The following is a description of a gene set: species: Mus musculus Any process that results in a change in state or activity of a cell (in terms of movement, secretion, enzyme production, gene expression, etc.) as a result of an oxygen-containing compound stimulus. Mouse Gene Set: GOBP_CELLULAR_RESPONSE_TO_OXYGEN_CONTAINING_COMPOUND, and this is the list of marker genes: Fpr-rs6, Lhcgr, Slc9b2, Mgarp (mitochondria localized glutamic acid rich protein), Snx5, Htr4, Cps1, Zfp106 (NCBI Gene Id 22647), Birc5, Large1, Mir23a, Agtr2, Nos3, Mir29b-2, Gbp2, Sorbs2, Csrp3, Brinp2, Stat5a, Htr2a, Cul3, Sirt6, Anxa1, Rapgef2, Slc2a5, Gnai1, Ptger4, P2ry12, Zc3h12a, Mir320, Cers1, Cdc5lrt6, Ctsd, Mir467d, Cd55, Mir431, Kank1, Ly6a, Msn, Mup4, Cfh, Dnmt1, Chrne, Zbed6, Tead2, Chrnb1, Blvrb, Psen1 (presenilin 1), Ppm1e, Hcn4, Plscr1, Pcsk9, Acaca, Ly86, Ppp1r9b, Akt1, Fgf23, Gper1 (NCBI Gene Id 76854), Pcna, Cyfip1, Klf16, Lcor, Hdac8, Ddias, Rps3, Pax6, Hmgcr, Map4k4, Oprm1, Slc12a2, Cacnb1, Tbc1d4, Lcn2, Mir29a, Gstp1, Pdcd4, Spidr, Brinp1, Mir208b, Rps6kb1, Plcg2, Ccl2, Kcnc2, Drd4, Ephb3, Mup3, Agtr1b, Ercc6l2, Kcnb1, Mir202, Npr2, Socs3, Acod1, Pik3r2, Trpa1, Crh, Mir30b, Pax2, Mettl21c, Sirt1, Txn1, Gpr39, Brip1 (BRCA1 interacting protein C-terminal helicase 1), Mir296, Rhoq, Trim41, Ddx11, Slurp2, Mir376c, Adh4, Prkn, Fbn1, Drd3, Htr7, Adipor2, Rack1, Ankrd1, Cdc5lrt1, Rps6, Stx4a, Akap9, Cd55b, Gclm, Gpr173, Irgm1, Slc26a3, Arid5a, Snx6, Twf2, Mir496a, Mir224, Kcnmb1, Prkci, Pabpn1, Eprs1, Mt3, Eif4e, Nr2c2, Ly6g6e, Stat5b, Ptpn2, Ndufa13, Ugt1a1, Cxcl16, Ncoa6, Rock1, Lin28a, Chrng, C2cd2l, Selenot, Erbb2, Wnt5a, Ptpn22, P2ry6, Nr1h4, Htr2b, Tgfb1, Pik3ca, Mir9-1, Htr3b, Rab11fip2, Drd1, Tesc, Prkca, Il36rn, Slc6a4, Phip, Prkd1, Ptgfr, Mir323, Nr1h3, Cldn1, Nadk, Mir544, Irf8, Chrm4, Ggcx, Htra2, Gjb6, Pink1, Lrp5, Fam114a1 (NCBI Gene Id 68908), Igf1r, Nr3c2, Marcks, Socs1, Klf4, Tnc, Klf2, Ano1, Lgmn, Eif4ebp2, Ly6g6d, Rapgef1, Igtp, Oxr1, Rgs10, Map3k7 (NCBI Gene Id 93774), Slc26a6, P2rx3, Rnf146, Adcy6, Scnn1b, Aqp8, Jak3, Epsti1, Htt, Rgs9, Mstn, Epha8, B2m, Pih1d1, Adcy7, Mir27a, Mir654 (NCBI Gene Id 100124453), Mir130a, Trim55, Add1, Ctr9, Mir223, Ripk1, Net1, Litaf, Lpin2, Vamp2, Smo (NCBI Gene Id 319757), Cdkn2a, Mir16-2, Casp1, Foxo3, Agap3, Mir511, Hnrnpu, Casp9 (NCBI Gene Id 12371), Agap2, Glra1, Rptor, Ednrb, Kcnk2, Bcar3, Pdx1, Mir1897, Akt3, Foxp1, Shoc2, Lpin1, Mapk13, Mir107, Mir217, Gclc, Slc12a7, Mir672, Cygb, Ogg1, Wnt10b, Mtr, Gria1, Prkcd, Defa23, Nfkb1, Trim12a, Hspa8, Gnaq, Defa24, Fgfr2, Traf6, Pde3a, Adcy3, Fut7, Slc8a3, Yes1, Klf7, Ptpn11, Tifab, Foxa1, Dynap, Ezr, Ces1c, Pdgfra, Mgst1, Glp1r, Mif, Hmgcs2, Cd68, Prdx3, Prkar1a, Tshr (NCBI Gene Id 22095), Calcrl, Ptk2b, Ntrk2, Lmnb1, Ncstn, Smyd3, Smad2, Hcn3, Trerf1, Piwil4 (NCBI Gene Id 330890), Shpk, Rnf4, Got1, Esrra, Bcr, Aldh2, Ppbp, Lep, Nanog, Hrh4, Epha10, Timeless, Traf2, Irak1, Mir376a, Tut4, Golph3, Grb14, Sipa1, Rad51, Ehmt2, Rhob, Cpt1a, Capn2, Defa35, Mir152, Aqp4, Cd80, Atp2b4 (ATPase, Ca++ transporting, plasma membrane 4), Fxn, Gpx1, Castor1, Nfkbib, Mir376b, Dtnbp1, Defa2, Defa39 (defensin, alpha, 39), Prmt5, Sos1, Malt1, Cav2, Map2k6, Pou4f1, Tnip2, Klrk1, Hmga1, Defa25, Zfp36l1, Trpm5, Anxa5, Bad, Rab11fip5, Havcr2, P2ry4, Mmp2, Pdxp (pyridoxal (pyridoxine, vitamin B6) phosphatase), Sybu, Pdk2, Vsnl1, Abl2, Vim, Defa30, H2az1, Trim72, Vps54, Mir486, Cacna1d, Atp5f1a, Igfbp1, Slc5a5, Rps6ka2, Epha3, Brsk2, Glra3, Crtc1, Orai1, Mir155, Bglap3, Atp2b1, Cib2, Bpi, Atg7, Pde4d, Slc29a1, Cx3cr1, Abcc8, Tlr9 (toll-like receptor 9), Slc1a1, Mir194-1, Ly6m, Prkdc, Lepr, Mir194-2, Pdgfb, Cxcl15, Kcne1, Ramp3, Ryr3, Egfr, Trim30b, Gkap1, Sco1, Mir362, Oaz1, Mir181b-2, Halr1, Gjb2, Plaa, Atp1a3, Pde4c, Mir23b (NCBI Gene Id 387217), Hoxa2, Nkx6-1, Map2k7, Gpd1, Cebpe, Pak1, Musk, Icam1, Gramd1b, Rorc, Gch1, Prnp, Actb, Trem2 (triggering receptor expressed on myeloid cells 2), Mir383, Cyp11b1, Ghsr, Adrb2, Egr1, Mir409, Gna14, Tbc1d1, Inhba, Cpeb1, Chrm5, Akap6 (A kinase anchor protein 6), Cdc5lrt5, Cacna1a, Chrm3, Ccl28, Mir30c-1, Bmi1, Raf1, Dnai1, Mup11, Hnrnpk, Rfx6, Mdm2 (NCBI Gene Id 69330), Ptpn6, Dhx36, Ager, Lrrk2, Igf2, Ccr5, Mir337, Ect2, Usf2, Vps35, Slc38a2, Tlr4, Abcb1a, Dgkq, Mup2, Mir192, Zfp683, Pycard, Grb10, Taar1, Lncbate10, Kcnk4, Ly6g6g, Trim63, Cyp24a1, Dnm2, Upf1, Pip4k2a, Ly6g2, Mir598, Mirlet7g, Cul7, Spp1, Cmpk2, Ghrl, Cd300lb, Hsf1, Ahsg, Recql5, Akap7, Defa37, Ly6h, Echdc3 (enoyl Coenzyme A hydratase domain containing 3), Romo1, Mir425, Gprin3, Socs7, Mir30e, Cyp1b1, Postn, Meiosin, Creb1, Lpar1, Il36b, Defa41, Dapk1, Rara, Mir494, Glp2r, Zbtb20, Adipoq, Rela, Id3, Ptgs2, Ptprj, Apoa4, Bcl10, Raet1d, Plcb1, Oxct1, Gbp2b, Nucks1, Sri, Kdm1a, Sgcb, Thbs1, Chrna6, Fancb, Ide, Adrm1, Mmp8, Crygf, Cdc5lrt9, Aldh1a7, Cacna1e, Xrcc5, Anxa7, Nucb2, Gdap1, Rragd, Gfi1, Ywhag, Mmp9, Il36a, Slc39a14, Trp53, Cdk1, Mir30a, Mir146b, Sgk1, Gcgr, Spi1, Defa5, Psca, Inhbb, Phex, Atp7a, Myod1, Chrm2, Btk, Trap1, Ros1, Epha5, Cflar (NCBI Gene Id 98571), Foxo1, Oser1, Eif4ebp1, Pdcd1lg2, Ppef2, Rorb, Trim24, Mpc2, Ly6f, Pde8b, Gas6 (NCBI Gene Id 14456), Chrna5, Pid1, Aldh1a1, Snw1, Sesn2, Mir410 (NCBI Gene Id 723863), Nfe2l2, Mertk, Mir200a, Grin2d, Cpeb2, Becn1, Cx3cl1, Epha4, Shmt1, Mir15a, Irs2, Zdhhc7, Kit, Ncoa1, Max, Chrna3, Mir484, Il1b, Prkcq (protein kinase C, theta), Adipor1, Chrna7, Epha1, Ptprv, Tet1, Mir379, Phox2b, Akt2, Trpc6, Fpr2, Chuk, Tbx1, Cdc5lrt7, Dab2ip, Agtr1a, Gdnf, Chrnb4, Pex2, Mir9-3 (microRNA 9-3), Ankk1, Eny2, Mir24-1, Ghrhr, Akr1c12 (aldo-keto reductase family 1, member C12), Smarcc1, Gja1, Grb7, Sstr1, Sesn1, Mapk3, Wdtc1, Inppl1, Mir369, Irak4, Inpp5k, Ly6c2, Zfand1 (NCBI Gene Id 99875), Ces1f, Ctnnb1, Cxcl13, Plscr3, Tjp1, Uchl3, C1qtnf12, Syk, Defb25, Aanat, Adprs, Defa29, Ruvbl2, Gna15, Trim30a (NCBI Gene Id 20128), Hdac2, Agt, Crhr2, Parp1, Ncoa2, Crhr1, Syap1, Insig2, Chek2, Hes1, Cyp11a1, Fcgr2b (NCBI Gene Id 98391), Gramd1c, Six1, Sesn3, Stk25, Csk, Irf3, Jup, Rab8a, Scimp, Irf1 (NCBI Gene Id 16362), Gnai3, Trpm4, Oprd1, Ubr2, Fam210b, Trp53inp1, Trim12c, Pjvk (pejvakin), Cyp11b2, Ptch1, Srf, Trib1, Mrc1, Rgs8, Ptpra, Mir22, Mirlet7a-2, Flt4 (NCBI Gene Id 14257), Tnip3, Mpv17, Psap, Prpf8, Rbm4, Mst1r, Ces1a, Dynll1, Nod2, Stim1, Fer, Cd14, Gramd1a, Gsk3a, Cdh1, Slc7a5, Il6, Abca1, Rhoa, C2cd5, Efnb2, Pla2g6, Prmt1, Cfl1, Ceacam1, Sos2, Itga2, Irak3, Gpam, Rb1, Socs2, Osr1, Capn10, Npas4, Ins2, Tbx2, Mir30c-2, Fbp1, Ptpn1, Zfp703, Cxcl9, Ccs, Ptgdr, Amigo1, Defa3, Bcl2l2, Cdc5lrt8, Lpl, Ezh2, Gbp6, Akr1c18, Myog, Git1, Pdia3, Myo5a, Nono, Mir199a-1, Ppp3ca, Cdk4, Gjb3, Serpina12, Nck1, Mir667, Irak2, A1bg, Mir142, Pparg, Ly6i, Mir487b, Srebf1, Mir7-1, Casp7, Mir342, Rab34, Zfp36, Ip6k2, Smad4, Fpr-rs4, Gria2, Car2, Mir29c, Il18, Keap1, Prkcb, Epha6, Rapgef3, Mir140, Ang2, Vcp, Nrip1, Ncam1, Fdx1, Irs1, Slc12a6, Adcy8, Jak1, Rplp0, Yap1, Ltf, Mir495, Plscr4, Slc30a10, Cltrn, Cav1, Kcnq1, Erbb4, Ndel1, Mir29b-1, Nfkbia, Sox10, Gprc6a, Trex1, Gata1, Rora, Unc13b, Chrnd, Hcn1, Pck1, Rgs4, Ephb2, Mir205, Defb21, Osbpl8, Map4k1, Tra2b, Mir3099, Hmgb1, Cryge, Ireb2, Blvra (NCBI Gene Id 70105), Rdh12, Txndc2, Tyro3, Ogt, Prdx1, Ankrd26, Appl1, Vcam1, Zfp277, Ep300, Cebpb, Mt1, Hnrnpd, Lilrb4a, Ccdc186, Akap8, Kcnj11, Hras, Rarg (NCBI Gene Id 19411), Twnk, Gpr37, Mir26b, Slc2a2, Hadhb, Actn2, Ltk, Ctnna1 (NCBI Gene Id 66546), Nr4a1, Phc1, Tie1 (NCBI Gene Id 21846), Kmo, Bmp4, Pten, Ly96, Umodl1, Itpr1, Gpr68, Kat5, Th, Capn1, Map2k1, Fpr-rs3, Pik3cg, Hdac9, Mir293, Abca12, Rbx1, Opa1, Msx2, Ass1, Hpca, Smarcd1, Rap1a, Elk1, Lpin3, Hsp90b1, Aifm1, Insrr, Mapk7, Pklr, Akr1c19, Xbp1 (NCBI Gene Id 52219), Tns2, Erfe, Foxo4, Trib3, Mir146, Crtc3, Osbpl7, Hcn2, Rxrb, Dynapl1, Il10, Blm, Grb2 (NCBI Gene Id 14784), Mir3072, Adamts13, Il1a, Nqo1, Pkm, Hif1a (hypoxia inducible factor 1, alpha subunit), Cd180, Bnip3, Ces1b, Ephb4, Tiam1, Axl, Sstr3, Kif5b, Sox4, Ptk7, Lonp1, Slc39a9, Gnai2, Fbxw8, Slc23a2, Klhl22, Penk, Gpt, Cacna2d1, Camk2a, Camk2n1, Trim30c, Lyn, Abcc1, Ppif, Gm527, Smarca4 (NCBI Gene Id 20586), Kdm6a, Nr4a2, Esd, Gck, Igf1, Ces1e, Prkce, Bcar1, Uso1, Sfrp1, Ffar3, Slc1a3, Pex5, Mir501, Ace, Adam15, T, Rps6kb2, Apc, Fkbp1b, Tcf7l2, Nod1, Myo1c, Aicda, Pdk3, Stxbp4, Scnn1g, Ccna2, Sorl1, Abcb4, Drd5, Ncoa3, Fcgr4, Ucp1, Chrna4, Pex13, Mir666, Esr1, Mtcl2, Pim1, Fbln5 (fibulin 5), Mir139, Cdc5l, Mir7-2, Gpbar1, Ppard, Tnfrsf1b, Mir181a-1, Mbd5, Rwdd1, Ceacam2, Vwa2 (NCBI Gene Id 240675), Fabp1, Chrnb3, Slc2a8, Lbp, Ngb, Ppara, Pdk4, Il18rap, Tnip1, Ubr1, Mir143 (NCBI Gene Id 387161), Mir26a-2, Gpr155, Cdc5lrt10, Cybb, Smad3, Sstr2, Grm5, Osbp, Ces1h, Ghr, Slc1a2, Htr2c, Foxa2, Nfe2l1, Cpb2, Leprot, Mir26a-1, Gna11, Palm, Itpr2, Gucy1b1, Mmp3, App, Ednra, Chrna2, Hmgb2, Stc1, Akr1b1, Shc1, Pde2a, Gnrhr, Larp1, Cdc5lrt4, Stat1, Cyp26a1 (cytochrome P450, family 26, subfamily a, polypeptide 1), Mb, Mir147 (NCBI Gene Id 387165), Atm, Arpc2, Prkaa1, Jagn1, Klf9, Ern1, Mir21a, Akr1a1, Ly6c1, Sod3, Pxn, Folr2, Rap1b, Gpld1, Insr, Hk3, Lynx1, Tnfsf4, Tescl, Ccl27a, Prkcz (protein kinase C, zeta), Sash1, Mir184, Flt3, Slit2, Ang4, Cxcl10, Adcy1, Fos, Obp2a, Arrb1, Tyk2, Ucp2, Dennd4c, Ripk2, Oprk1, Sorbs1, Prdx2, Nfkbiz, Ddr1, Brca1, Neurod1, Map1lc3a, Tunar, Myh9, Ptprn2, Cdk19, Avpr1a, Fancc (NCBI Gene Id 14088), Ptk2, Rps6-ps4, Sox9, Rdh11, Snhg20, Cr2, Map2k4, Pf4, Mir199a-2, Dgat2, Mup1, Ngfr, Ugt3a1, Park7 (NCBI Gene Id 57320), Mir345, Crkl, Cdk2, Or51e2, Hnf1a, Fgfr1, Trarg1, Defa38, Pck2, Rangap1, Zfp592, Aldh1a2, Defa34, Map3k5, Foxc2, Mapk8, Tirap, Mapk14, Mapk9, Serpine1, Appl2, Reg1, Slc27a1, Gnal, Defa31, Rab10, Bace1, Cdk16, Kif18a, Ptger3, Tmigd1, Rhox13, Smpd3, Ptk6, Eef2k, Il1f10, Cxcl2, Prkaca, Bglap2, Glra2, Enpp1, Tek, Fgfr4, Gnb5, Mtdh, Flna, Mir154, Igfbp5, Ptpmt1, Chrm1, Mlxipl, Dmtn, Ifng, Otop1, Sidt2, Ssh1, Ret, Phb2, Plekha1, Bmt2, Mir145a, Defa20, Slc27a4, Afg3l1, Camp, Pim3, Mup5, Pkd2, AY761185, Btg2, Pde4b, Baiap2, Star, Rac1, Aqp1, Prkaa2, Drd2, Kbtbd2, Grin3b, Mtor, Pex10, Adcy2 (NCBI Gene Id 238696), Rxra, Map2k3 (NCBI Gene Id 26397), Stambpl1, Mir193a, Ncoa5, Sod1, Cyp26b1, Fech, Pde1c, Nr3c1, Ifnb1, Pex14, Serpinf1, Gfer, Aacs, Ly6g, Nr4a3, Stap1, Adh5, Pex12, Endog, Med1, Nr1d1, Col1a1, Mas1, Mir543, Gcg, Gbp10, Apex1, Grk2, Slc9a1, Pik3r1, Src, Nos2 (nitric oxide synthase 2, inducible), Bglap, Edn1, Crtc2, Crygd, Arhgef2 (Rho/Rac guanine nucleotide exchange factor 2), Dpep1, Ldoc1, Afg3l2, Abl1, Gnas, Top2b (NCBI Gene Id 319393), Adra2a, Comt, Pdgfrb, Mir9-2, Irgm2, Ndufaf2, Ugt3a2, Flt1, Gpr37l1 (G protein-coupled receptor 37-like 1), Gpr27, Snai2, Ntrk1, Col6a1, Mir182, Lrp8, Rab11b, Slc8a1, Epha2, Sh2b2, Ranbp1, Nfatc4, Fbxo32, Ces1g, Cftr, Efna5, Pde3b, Stra8, Nppc, Gdf15, Fpr-rs7, Tgm2, Kat2b, Mn1, Hand2, Trim30d, Hmgn3, Pdgfd, Kdm6b, Cxcl5, Kdr, Defa17, Tspo, Myd88, Ahr, Mir500, Ambp, Prdx5, Rpl23, Cdk5, Ddr2, Cyp7a1, Csf1r, Bmp6, Defa42, Crhbp, Mir532, Tead1, Aqp2, Mpo (myeloperoxidase), Dnmt3a, Mef2c, Il12b, Tnfaip3, Mir30d, Ptger1, Mir433, Baiap3, Krt13, Akr1c13, Wnt1, Irs4, Mapkap1, Sphk1, Htr6, Ppp3cb, Jun, Htr1a, Cactin, Cd84, Ptpre, Gbp3, Sik2, Ces1d (NCBI Gene Id 104158), Mir377, Aplp1, Cdc73 (NCBI Gene Id 96910), Nherf1, Mir339, Lypd1, Il36g, Dag1, Mir181c, Scarb1, Myt1, Ryr1, Gnao1, Hoxa1, Cyp27b1, C1qtnf9, Mir125a, Mir7b, Mat2a, Defa21, Setx, Lrp1, Hcfc1, Sirpa, Cav3, Map1b, Chrnb2, Mir24-2, Rock2, Zbtb7b, Cd274, Csf3, Cd36 (NCBI Gene Id 12491), Scnn1a, Dhfr, Spon2, Nptx1, Ncl, Fyn, Trim5, Stat6, Mlc1, Chrna1, Sgms1, Ar, Slc25a33, Gata5, Itpr3, Mir98, Gpr21, Grip1, Ptger2, Ptprf, Pip4k2c, Kank2, Cdk5r1, Rarres2, Pou4f2, Nuggc, Ahcyl1, Pcgf2, Cd6, Chmp5, Rap1gds1, Apoc3, Leprotl1, Cd86, Mir381, Ntrk3, Gbp5, Casr, Defa22, Mir301 (microRNA 301), Adcy5, Srsf3, Ankzf1, Pdpk1, Mir350, Ffar2, Tsc2, Ins1, Ache, Slc2a4, Folr1, Ror2 (receptor tyrosine kinase-like orphan receptor 2), Defa28, Adam9, Tlr6, Tbxa2r, Lancl2, Pip4k2b, Castor2, Gh, Itgb3, Ripk3, Nme8, Sphk2, Brinp3, Gsk3b, Jak2 (Janus kinase 2), Ptprn, Tlr2, Mir539, Usf1 (upstream transcription factor 1), Mir181a-2 (NCBI Gene Id 387176), Nox4, Hgf, Ly6e, Insig1, Pdcd10, Ddit4, Trpm2 (transient receptor potential cation channel, subfamily M, member 2), Lars1, Irs3, Sin3a, Nfkbil1 (nuclear factor of kappa light polypeptide gene enhancer in B cells inhibitor like 1), Vdr, Ppp1r1b (protein phosphatase 1, regulatory inhibitor subunit 1B), Mir150 (microRNA 150), Sod2, Pik3r3, Fes, Paf1, Sp1, Esr2, Ctsg, Zfp580, Mir210, Met, Ccl7, Smarcb1, Ccdc62, Ldlr, Axin2, Htr3a (NCBI Gene Id 15561), Ephb1, Rab31, Il12a, Nlrp3, Mfn2, Tnf, Sbno2, Crk, Ticam1, Ticam2, Mzb1, Trpv1, Mir200c, Abcg1, Hdac6, Alk, Mir10a, P2rx4 (NCBI Gene Id 52272), Trpc1, Ptafr, Pawr, Selenos, Agtrap, Itga4, Fto (FTO alpha-ketoglutarate dependent dioxygenase), Defa26, Ptprk, Stat3, Lrp6, Cbx8, Fgfr3, Cat, Mapk1, Mir10b, Ppargc1b, Plscr2, Abcc9, Epha7, Plec, Rab13, Defa40, Mir382, Hrh3